The following is a description of a gene set: from publication Yang XD, Ai W, Asfaha S, Bhagat G, Friedman RA, Jin G, Park H, Shykind B, Diacovo TG, Falus A, Wang TC (PMID 21170045) Differentially expressed genes of CD11b+Gr-1+ immature myeloid cells (IMCs) in the bone marrow and colonic tumor setting of histidine decarboxylase (HDC)-KO mice were examined by microarray (Affymetrix Mouse 430.2 array). Myeloid differentiation-related candidate genes were sought to be isolated and functionally studied. Genes up-regulated in myeloid-derived suppressor cells from colon tumors: wildtype versus HDC knockout. Human Gene Set: GSE23502_WT_VS_HDC_KO_MYELOID_DERIVED_SUPPRESSOR_CELL_COLON_TUMOR_UP studied in species Homo sapiens, and this is the list of marker genes: DLGAP5, VCAM1, NCK1, P2RX7, EMILIN2, FSD2, TPX2, FCGR2A, SEC24D, ROM1, KATNB1, FPR2, SLPI, IFIH1, RGS2, FUOM, GJB6, ARHGAP19, SHCBP1, MCM6, PBK, IGSF6, GLUL (NCBI Gene Id 2752), USP1, PHGDH, AICDA, CHID1, FYB1, ETV5, MKI67 (NCBI Gene Id 4288), MAF, ACP7, TNFAIP2, IFITM2, PLK3, JKAMP, PHACTR2, XPO5 (exportin 5), GPT2, MGST1, UBE2C, GBP2, S1PR2, CSF3R, SLC40A1, C5AR1, FAM72A, XCL1, HMGB2, CTDSPL, DUSP1 (NCBI Gene Id 1843), CXorf49B, ZEB2, KNTC1, YWHAH, SPON1, MTUS1, RACGAP1, AP1M2, SMPD3, GNB4, CCNA2, TXN, ST7, GDA, CKS1B, NELFCD, LIN54 (NCBI Gene Id 132660), S100A8, GCSAM, BATF3, CYP24A1, CDCA5, CDCA3, IL7R, CCNB2, TGM2, ATP11A, PLIN2 (NCBI Gene Id 123), FAM181A, RGS13, ADK, CDC45, UBE2S, DNAJC21, CPSF4L, FAH, STS, DHFR, C3orf70, IL3RA, RAB32, PORCN, CRB3, HELZ, TAGLN2, PROSER2, BST1, STMN1, CDC14B, CTSB, MIER1, FOSL2, CKS2, IFIT3, TENT5C, TADA2A, PDK3, LDHA, CLEC6A, IL1B, DUOX1, HSPA2, TMEM38B, SASH1, LONP2, CFP, RABEPK, TOP2A, FAM221A, NEK6, CKAP2L, TMEM214, CLEC1B, GFRA2, ELMO3, INSL6, IFT74, SELENOP, APOE, TPMT, MRC1, IFITM3 (NCBI Gene Id 10410), ADGRL2, ERICH6, TBC1D31, RRM2, PCLAF, TRIP13, KIFAP3, PAQR9, FZD4, SPEN, EAF2, MAN2B2, PAWR, MDH2, BUB1B, CREG1, TRA2A, HMMR, CLTB, TOX, CDKN2C, CLEC7A, KLF10, CDKN3 (cyclin dependent kinase inhibitor 3), HELLS, BIRC5, HACD1, CELSR2, BCKDHA, XRN1, LTBP3, SLC11A1, BASP1, GTPBP3, PILRB, CENPS, ZNF862, C1QB (complement C1q B chain), SST, KCNN4, NUF2, PILRA, MYB, ADA, SORD, ANLN, PYROXD2, BUB1, S100A9, SPAG5, HNRNPUL2, TCEANC2, TMEM176B, FCGR3A, USP14, CAPN10, CDK1, TFDP2, GBP6, SLFN12, PAIP2, TTLL11, KLF9, ADGRE1, CITED2, ARHGEF10L, SYT12